Given this list of marker genes LUM, STAT4, GPHN, CTSC, CD36, RBL1, RHD, S100A9, DNAJB1, NFATC3, XPO1, PTPN22, SEC61A1, DTD1, ACTN4, SMC4, JOSD1, PLET1, PDK1, VKORC1, SET, LCP1, ROM1, HMBS, PIP4K2A, ST3GAL6, ANP32B (acidic nuclear phosphoprotein 32 family member B), NUMA1, PSMB8, EIF4E, CDCA4, ISOC1, C1QBP, ABR, RPS2, TUBA1B, CA2, GIMAP4, COX18, SSBP2, BRPF1 (bromodomain and PHD finger containing 1), ASXL1, ID3, FXYD5, IFRD2, CCND2, SLC20A1, RBBP7, CDKN1A, DERL2, DDX1, ISYNA1, STIL, NASP, PCK2, SLC25A20, MOGS, RPA1, HSPH1, ZYX, GBP4, BCL2, RPN2, PACS1, ATP1A1 (ATPase Na+/K+ transporting subunit alpha 1), EHD1, SGO1, ACP1, MEF2C, TUBB4B, TUBA4A, WDHD1, IER2, LYZ, CRIP2, here is a description of the gene set: Human Gene Set: MORI_SMALL_PRE_BII_LYMPHOCYTE_DN species: Mus musculus The Emu-myc transgenic mouse has provided a valuable model for the study of B-cell lymphoma. Making use of gene expression analysis and, in particular, expression signatures of cell signaling pathway activation, we now show that several forms of B lymphoma can be identified in the Emu-myc mice associated with time of tumor onset. Furthermore, one form of Emu-myc tumor with pre-B character is shown to resemble human Burkitt lymphoma, whereas others exhibit more differentiated B-cell characteristics and show similarity with human diffuse large B-cell lymphoma in the pattern of gene expression, as well as oncogenic pathway activation. Importantly, we show that signatures of oncogenic pathway activity provide further dissection of the spectrum of diffuse large B-cell lymphoma, identifying a subset of patients who have very poor prognosis and could benefit from more aggressive or novel therapeutic strategies. Taken together, these studies provide insight into the complexity of the oncogenic process and a novel strategy for dissecting the heterogeneity of B lymphoma. Down-regulated genes in the B lymphocyte developmental signature, based on expression profiling of lymphomas from the Emu-myc transgenic mice: the Small Pre-BII stage. from publication Mori S, Rempel RE, Chang JT, Yao G, Lagoo AS, Potti A, Bild A, Nevins JR (PMID 18922927)